Given this list of marker genes LTB4R2, PPARG, HPGD, PTGER3, PTGER4, PTGER1 (NCBI Gene Id 5731), CYSLTR2, PTGDR2 (prostaglandin D2 receptor 2), PTGFR, TBXA2R, LTB4R, PTGER2, CYSLTR1, PTGIR, PTGDR, here is a description of the gene set: Combining with an icosanoid to initiate a change in cell activity. Human Gene Set: GOMF_ICOSANOID_RECEPTOR_ACTIVITY species: Homo sapiens